Given this list of marker genes AGO1, TSNAX, AGO4, AGO3, TSN, DICER1, PRKRA, TARBP2, AGO2, here is a description of the gene set: Small interfering RNA (siRNA) biogenesis Human Gene Set: REACTOME_SMALL_INTERFERING_RNA_SIRNA_BIOGENESIS species: Homo sapiens